The following is a description of a gene set: The chemical reactions and pathways resulting in the breakdown of dUMP, deoxyuridine (5'-)monophosphate. Human Gene Set: GOBP_DUMP_CATABOLIC_PROCESS studied in species Homo sapiens, and this is the list of marker genes: UPP1, NT5M, DPYS, DPYD, UPB1, NT5C